Given this list of marker genes Rpa2, Nbn, Smg5, Hus1, Aurkb, Pot1a, Xrcc1, Zscan4f, Recql4 (NCBI Gene Id 79456), Dclre1c, Hnrnpu, Cdk2, Parp1, Uchl5, Terf2, Gar1, Brca2, Pot1b, Terf1, Cct2, Actr5, Mapk3, Tnks, Ino80b, Xrcc3 (X-ray repair complementing defective repair in Chinese hamster cells 3), Tert, Smc6, Tnks2, Ino80, Terc, Exosc10 (exosome component 10), Ino80d, Map3k4, Trp53, Nop10, Upf1, Pif1, Shld2, Ercc1, Pinx1, Hnrnpd, Atm, Nhp2, Rpa1, Ctc1, Xrcc6, Pml, Actr8, Mapkapk5, Nek7, Tinf2 (NCBI Gene Id 28113), Zscan4c, Ccne1 (cyclin E1), Mapk15, Ptges3, Dkc1, Atr, Zfp365, Pkib, Xrn1, Hsp90ab1, Gch1, Nek2, Slx4 (NCBI Gene Id 52864), Zscan4d, Pnkp (NCBI Gene Id 76351), Ten1, Ruvbl2, Nvl, Cct6a, Rad50, Smc5, Prkdc (NCBI Gene Id 19090), Apex1, Stn1, Terf2ip, Ccne2, Atrx, Xrcc5, Prkcq, Spdya, Hus1b, Dcp2 (NCBI Gene Id 70640), Parp3, Rad51d, Yy1 (YY1 transcription factor), Cct5, Dhx36, Pou5f1 (POU domain, class 5, transcription factor 1), Mad2l2 (NCBI Gene Id 71890), Naf1, Nat10, Potefam3b, Slx1b, Sirt6 (NCBI Gene Id 72769), Myc, Rad51, Ankrd66, Mcrs1, Hdac8, Cct3, Dna2, Tcp1, Fbxo4 (NCBI Gene Id 67521), Shld3, Tep1, Hsp90aa1, Hnrnpc, Ercc4, Gnl3 (guanine nucleotide binding protein nucleolar 3), Nfrkb, Shld1, Potefam3a, Wrn, Hspa1a, Sp100, Ruvbl1, Ctnnb1, Actl6a, Cct8, Ppp1r10 (NCBI Gene Id 66450), Gnl3l, Parn, Ppp1ca, Tfpt, LTO1, Nhej1, Mapk1 (mitogen-activated protein kinase 1), Rtel1, Pcna, Lrrc34, Blm, Rad51c, Nsmce2, Mre11a, Tent4b, Smg6, Zbtb48, Smg1, Cct7, Map2k7, Bmyc, Nabp2, Klf4, Zfp827, Wnt3a, Ptges3-ps, Xrcc4, Dclre1b, Wrap53, Src (Rous sarcoma oncogene), Hnrnpa2b1, Ylpm1, Parp4, Acd, Rif1, Ino80c, Lmna, Hmbox1, Cct4, here is a description of the gene set: Any process that contributes to the maintenance of proper telomeric length and structure by affecting and monitoring the activity of telomeric proteins, the length of telomeric DNA and the replication and repair of the DNA. These processes includes those that shorten, lengthen, replicate and repair the telomeric DNA sequences. Mouse Gene Set: GOBP_TELOMERE_MAINTENANCE studied in species Mus musculus